Given this list of marker genes Degs1, Jund, Tpst1, Lcp2, Top1, Msr1, Igtp, Atf3, Kpna3, Cflar, Rgs16, Hmgcr, Bcl2l1, Pml, Slfn3, Tnfrsf1b, Nfkb1, Ptgs2, Ifrd1, Slc20a1, Prkcd, Rcn1, Mapkapk2, Stat1, Gch1, Furin, H2-T22, Ets2, Txnrd1, Ifi202b, Cited2, Eif1, Tap1, Sat1, Fcgr2b, Myadm, Dab2, Mllt11, Slpi, Srgn, Odc1, Rhoc, Mt2, Pip5k1b, Glrx, Il1rn, C3ar1, Lilrb4a, Slc11a1 (solute carrier family 11 (proton-coupled divalent metal ion transporters), member 1), Lilrb4b, Sqstm1, Wsb1, Casp4, Bcl6b, Clec4d, Cebpd, Ier3, Cdkn1a, Sap30, Ccl3, Gk, Irgm2, Tnf, Hcls1, Apbb1ip, Etf1, Nfkbia, Slfn2, Ltb, Tnfsf9, Map2k1, Trim25 (tripartite motif-containing 25), Ccl9, Ier2, Hck, Il1rl1, Tnip1, Rnf11, Acsl4, Marcksl1, Slc2a1, Myo10, Slfn4, Adar, Cln3, Tgfb1, Cd44, Ifi204, Stk10, Pnp, here is a description of the gene set: Mouse Gene Set: NEMETH_INFLAMMATORY_RESPONSE_LPS_UP species: Mus musculus Adenosine is released into the extracellular space from nerve terminals and cells subjected to ischemic stress. This nucleoside modulates a plethora of cellular functions via occupancy of specific receptors. Adenosine is also an important endogenous regulator of macrophage function, because it suppresses the production of a number of proinflammatory cytokines by these cells. However, the mechanisms of this anti-inflammatory effect have not been well characterized. We hypothesized that adenosine may exert some of its anti-inflammatory effects by decreasing activation of the transcription factor nuclear factor-kappaB (NF-kappaB), because gene expression of most of the proinflammatory cytokines inhibited by adenosine is dependent on NF-kappaB activation. Using bacterial lipopolysaccharide (LPS)-stimulated RAW 264.7 macrophages, we found that adenosine as well as adenosine receptor agonists decreased the production of tumor necrosis factor (TNF)-alpha, a typical NF-kappaB-regulated cytokine. This effect of adenosine was not due to an action on the process of TNF-alpha release, because adenosine suppressed also the intracellular levels of TNF-alpha. However, cDNA microarray analysis revealed that mRNA levels of neither TNF-alpha nor other cytokines were altered by adenosine in either LPS-activated or quiescent macrophages. In addition, although LPS induced expression of a number of other, noncytokine genes, including the adenosine A2b receptor, adenosine did not affect the expression of these genes. Furthermore, adenosine as well as adenosine receptor agonists failed to decrease LPS-induced NF-kappaB DNA binding, NF-kappaB promoter activity, p65 nuclear translocation, and inhibitory kappaB degradation. Together, our results suggest that the anti-inflammatory effects of adenosine are independent of NF-kappaB. Genes up-regulated in RAW 264.7 cells (macrophage) 3 hr after stimulation with bacterial lipopolysaccharide (LPS). from publication Németh ZH, Leibovich SJ, Deitch EA, Vizi ES, Szabó C, Hasko G (PMID 12766259)